The following is a description of a gene set: Mouse Gene Set: GOMF_L_GLUTAMINE_TRANSMEMBRANE_TRANSPORTER_ACTIVITY species: Mus musculus Enables the transfer of L-glutamine from one side of a membrane to the other. L-glutamine is 2-amino-4-carbamoylbutanoic acid., and this is the list of marker genes: Slc38a1, Slc38a6, Slc38a7, Slc1a5, Slc38a3, Slc38a2, Slc38a9, Slc38a5